Given this list of marker genes Ap2a1, Rps27a, Ap2s1, Ubb, Vldlr, Ap2b1, Ap2m1, here is a description of the gene set: part of: Plasma lipoprotein clearance electronically inferred by orthology from the curated human pathway Reactome Pathway: VLDLR internalisation and degradation species: Mus musculus This event has been computationally inferred from an event that has been demonstrated in another species.<p>The inference is based on the homology mapping from PANTHER. Briefly, reactions for which all involved PhysicalEntities (in input, output and catalyst) have a mapped orthologue/paralogue (for complexes at least 75% of components must have a mapping) are inferred to the other species.